The following is a description of a gene set: studied in species Mus musculus Mouse Gene Set: GOCC_COLLAGEN_TYPE_IX_TRIMER A collagen heterotrimer containing type IX alpha chains in alpha1(IX)alpha2(IX)alpha3(IX) trimers; type IX collagen triple helices associate to form a structure that links glycosaminoglycans to type II collagen fibrils., and this is the list of marker genes: Col9a2, Col16a1, Col13a1, Col9a1, Col9a3